The following is a description of a gene set: Down-regulated genes defining rejection of mammary carcinoma (MMC) tumors. Mouse Gene Set: WORSCHECH_TUMOR_REJECTION_DN species: Mus musculus We have previously shown T-cell-mediated rejection of the neu-overexpressing mammary carcinoma cells (MMC) in wild-type FVB mice. However, following rejection of primary tumors, a fraction of animals experienced a recurrence of a neu antigen-negative variant (ANV) of MMC (tumor evasion model) after a long latency period. In the present study, we determined that T cells derived from wild-type FVB mice can specifically recognize MMC by secreting IFN-gamma and can induce apoptosis of MMC in vitro. Neu transgenic (FVBN202) mice develop spontaneous tumors and cannot reject it (tumor tolerance model). To dissect the mechanisms associated with rejection or tolerance of MMC tumors, we compared transcriptional patterns within the tumor microenvironment of MMC undergoing rejection with those that resisted it either because of tumor evasion/antigen loss recurrence (ANV tumors) or because of intrinsic tolerance mechanisms displayed by the transgenic mice. Gene profiling confirmed that immune rejection is primarily mediated through activation of IFN-stimulated genes and T-cell effector mechanisms. The tumor evasion model showed combined activation of Th1 and Th2 with a deviation toward Th2 and humoral immune responses that failed to achieve rejection likely because of lack of target antigen. Interestingly, the tumor tolerance model instead displayed immune suppression pathways through activation of regulatory mechanisms that included in particular the overexpression of interleukin-10 (IL-10), IL-10 receptor, and suppressor of cytokine signaling (SOCS)-1 and SOCS-3. These data provide a road map for the identification of novel biomarkers of immune responsiveness in clinical trials. from publication Worschech A, Kmieciak M, Knutson KL, Bear HD, Szalay AA, Wang E, Marincola FM, Manjili MH (PMID 18381452), and this is the list of marker genes: Irf2bp1, Tnfrsf12a, Btla, Elp1, Tnfaip1 (NCBI Gene Id 21927), Irak1bp1, Bcap31, Ilf3, Tiam2, Ly6e